Given this list of marker genes Tsc22d3, Itga4, Septin9, Klhl24, Crip1, Emp3, Igkc, Fkbp1a, Ccdc88c, Rasa3, Clip1, Stk38, Pdcd4, Ppp1ca, Arhgap9, S100a13, Adcy7, Ankrd44, Prkacb, Ttc7, Septin1, Timp2, Esyt2, Ets1 (NCBI Gene Id 330916), Laptm5, Tdrp, Cirbp, Itga6, Cd3g, Celf2, Rnf167, Ramp1, Cox7a2l, Cd4, Capg, Klf3, Smc6, Myl6, Rab37, Ttc3, Trat1, Gm2a, Cd9, Tmem50a, Cd28, Gpsm3, Acp5, Psap, Orai2, Oxct1 (3-oxoacid CoA transferase 1), Npc2, S100a10, Tspan32, St8sia6, Gnai2, Trbc2, Ikbkb, Tnrc6b, Faah, Sh3bgrl3, Add3, Sptbn1, Hcst, Macf1, Rgs10, Adgre5, Arl5c, Skap1, Dapl1, Hvcn1, Ptpn18, Dgkz, Themis, Pdlim4, Znrf1, Pitpnc1 (phosphatidylinositol transfer protein, cytoplasmic 1), Lbh, Fxyd5 (NCBI Gene Id 18301), Smc4, S1pr1, Kif21b, Cd52, Prex1, Acaa2, Nsg2, Ripor2, Ypel3, Limd2, Cd5, Btg2, Rgcc, Akap13, Pycard, Thy1, Itgb7, Rasgrp2, Smad7, Actn1, Hsd11b1, Arhgap15, Dgka, Stmn1, Mgst2, Ldlrap1, Cd3d, Ucp2, Lsp1, Arhgdib, Dap, Fam78a, Mxd4, Rasgrp1, H2az2, Otulinl, Cotl1, Pik3ip1, Gmfg, Rcsd1 (NCBI Gene Id 77931), Cd48, Klf2, Ppdpf, Il7r, Madd, Pik3r1, Crlf3, Evl (NCBI Gene Id 14026), Lef1, Tecpr1, Cd96, Txnip, Cdc42ep3, Commd8, Arhgap45, Spn, Rassf2, Coro1a, Ighm, Slamf6, Smpdl3a, Srpk2, Slc44a2, Foxp1, Gramd1a, Atp1b3, Retreg1, Cd3e, Tbc1d10c, Selenop, Tagln2, Ppp1r18, Bin1, Arhgef18, Saraf, Cd37, St8sia1, Flna, Eef2, Bcl9l, St6gal1, Arhgef1, Zfp36l2, Myh9, Ctsd, here is a description of the gene set: from publication Cui A, Huang T, Li S, Ma A, Pérez JL, Sander C, Keskin DB, Wu CJ, Fraenkel E, Hacohen N (PMID 38057668) Genes negatively differentially expressed in cell type: CD4+ T cell upon treatment with cytokine: IL-36α in mouse lymph nodes in vivo. Mouse Gene Set: CUI_T_CELL_CD4_IL36A_RESPONSE_DN species: Mus musculus Cytokines mediate cell-cell communication in the immune system and represent important therapeutic targets. A myriad of studies have highlighted their central role in immune function, yet we lack a global view of the cellular responses of each immune cell type to each cytokine. To address this gap, the authors created the Immune Dictionary, a compendium of single-cell transcriptomic profiles of more than 17 immune cell types in response to each of 86 cytokines (>1,400 cytokine-cell type combinations) in mouse lymph nodes in vivo. A cytokine-centric view of the dictionary revealed that most cytokines induce highly cell-type-specific responses. For example, the inflammatory cytokine interleukin-1β induces distinct gene programmes in almost every cell type. A cell-type-centric view of the dictionary identified more than 66 cytokine-driven cellular polarization states across immune cell types, including previously uncharacterized states such as an interleukin-18-induced polyfunctional natural killer cell state.